The following is a description of a gene set: Genes predicted to be targets of miRBase v22 microRNA hsa-miR-6800-3p in miRDB v6.0 with MirTarget v4 prediction scores > 80 (high confidence targets). species: Homo sapiens from publication Chen Y, Wang X (PMID 31504780) Human Gene Set: MIR6800_3P, and this is the list of marker genes: ZMYM4, BRPF3, ZBTB10, GABBR2 (gamma-aminobutyric acid type B receptor subunit 2, NCBI Gene Id 9568), MAP4K5, SMG7, NAV2, MAP3K2, TBC1D30, AFDN, PAQR5, ZFHX4, ESR1, XPO4, RFESD, MCM9, GAB1, ZNF486 (NCBI Gene Id 90649), PPP1R13B, TRHDE, PTPRK, MCM4, TMEM39A, PNRC1, PIP4K2B, BHLHE40, ORC4, DPEP2NB, RPTN